The following is a description of a gene set: Mouse Gene Set: GOMF_DEAD_H_BOX_RNA_HELICASE_BINDING Binding to a DEAD/H-box RNA helicase. species: Mus musculus, and this is the list of marker genes: Etv3, Pot1a, Drosha, Smad5, Zc3hav1, Smad1, Smad3, Pot1b, Sp7